Given this list of marker genes RBP7, PLPP3, EDNRB, DHRS3, NOSTRIN, CA4, GYPC, OSBPL1A, STC1, DDIT4 (NCBI Gene Id 54541), TMEM204, CTSH, PLPP1, AKAP12, NKX2-3, CD36, NOTCH4, FCN3, GAS6, FXYD6, SPP1, RAMP3, RGCC, SGK1, TMEM88, ATOH8, MT1E, ITM2A, BTNL9, TSC22D1, NHERF2, SIPA1L2, ID2, CARHSP1, FAM167B, COL15A1, MT1X, CDC42EP4, DNASE1L3, MT2A, HLA-DQA1, TM4SF18, NQO1, VWA1, SELENOP, CD320, HES1, MLEC, F2RL3, MT1M, here is a description of the gene set: Human Gene Set: GAVISH_3CA_METAPROGRAM_ENDOTHELIAL_ENDO_7 from publication Gavish A, Tyler M, Greenwald AC, Hoefflin R, Simkin D, Tschernichovsky R, Galili Darnell N, Somech E, Barbolin C, Antman T, Kovarsky D, Barrett T, Gonzalez Castro LN, Halder D, Chanoch-Myers R, Laffy J, Mints M, Wider A, Tal R, Spitzer A, Hara T, Raitses-Gurevich M, Stossel C, Golan T, Tirosh A, Suvà ML, Puram SV, Tirosh I (PMID 37258682) Genes upregulated in subsets of cells of a given type within various tumors species: Homo sapiens In this study, an extensive analysis was conducted to define meta-programs (MPs) capturing intra-tumor heterogeneity across a spectrum of tumor types. The approach utilized non-negative matrix factorization (NMF) to analyze each cell type separately within individual tumor samples. This involved the analysis of malignant cells, macrophages, fibroblasts, endothelial cells, epithelial cells, T-cells, and B-cells. NMF was executed with varying parameter values (K=4, 5, 6, 7, 8, 9), thereby generating 39 programs for each cell type per sample. Each NMF program was summarized by the top genes based on NMF coefficients.\nRobust MPs were then delineated for each cell type using a set of stringent criteria, including recurrence within the same tumor, similarity to programs in other tumors, and non-redundancy within a tumor. Subsequently, these robust NMF programs were clustered (per cell type) based on Jaccard similarity, leading to the identification of MPs associated with each cell type.\nTo enhance the quality of the MPs, a refinement steps were undertaken, involving the removal of MPs suspected of reflecting low-quality data (with an overrepresentation of ribosomal proteins or mitochondrial-encoded genes), single-study inclusion, or similarity to miss-annotated cell types.